The following is a description of a gene set: species: Mus musculus Genes predicted to be targets of miRBase v22 microRNA mmu_miR_687 in miRDB v6.0 with MirTarget v4 prediction scores > 80 (high confidence targets). from publication Chen Y, Wang X (PMID 31504780) Mouse Gene Set: MIR_687, and this is the list of marker genes: Rabgap1, Slc2a4, Ascl2, Dcaf12l2, Slc24a2, Paqr8 (NCBI Gene Id 74229), Usp53, Sos2, Pde3b, Ints10, Mycbp2, Zfp945, Dsg2, 6430548M08Rik, Hormad2, Atp11c, Nars2, Suds3, Cyp2c37, Sp4, Sstr1, Irx2, Adam10, Saxo2, Homer1, Ninj2, Klf12, Zfp445, Plekho1, Vps26b, 2210408I21Rik, Cyp7b1, Mavs, Sfrp4, Met (met proto-oncogene), Ptpn12, Tmem229a, Clptm1, Peg10, Cpeb3, Crls1